The following is a description of a gene set: Deep anterior chamber Human Gene Set: HP_DEEP_ANTERIOR_CHAMBER Increased depth of the anterior chamber, i.e., the anteroposterior distance between the cornea and the iris is increased. studied in species Homo sapiens, and this is the list of marker genes: CYP1B1, TEK, CHRDL1, MYOC, LTBP2